The following is a description of a gene set: Any process that modulates the frequency, rate or extent of the directed movement of substances within cells. species: Mus musculus Mouse Gene Set: GOBP_REGULATION_OF_INTRACELLULAR_TRANSPORT, and this is the list of marker genes: Prkaca, Chp2, Gsk3b, Ddx39a, Mapk3, Pik3r1, Atp9a, Fez1, Gm14461, Prkcd, Ppp1cc, Asph, Arf1 (NCBI Gene Id 11840), Anxa2, Xpo1, Mapk8, Spag5, Nfkbia, Inpp5f, Mylk2, Cwh43, Pla2g3, Dynlt2b, Msn, Ncbp2, Dnajc13, Mtmr2, Pik3r2, Erlec1, Oaz3, Arv1, Akap5, Map1b, Flna, Cdk1, Nus1 (NUS1 dehydrodolichyl diphosphate synthase subunit), Pgap1, Ptpn1, Nefh, Angpt1, Hm629797 (cDNA sequence HM629797), Uhmk1, Nolc1, Nup62, Abca12, Tbc1d20, Ufm1, Rab11b, Anp32b, Bard1, Sorl1, Rab29, Numa1, Sar1a, Slc35d3, Xpo4 (NCBI Gene Id 78542), Cdc42, Yipf5, Rdx, Eipr1, Epm2a, Sh3glb1, Ubr5, Hdac3, Sirt6, Ei24, Chrm1, Nup153, Dab2 (disabled 2, mitogen-responsive phosphoprotein), Cpsf6, Prpf4b, Cnih2, Tpr, Nup54, Zfand1, Jup, Hyal2, Sirt7, Cdkn2a, Ndel1, Nrde2, Mavs, Strit1, Thoc5, Insig1, Cryaa, Pln, Vps35, Rangap1, Cryab, Zpr1, Ptpn14, Pla2g4e, Ndrg4, Hsp90aa1, Sfn, Hap1, Rbm4, Atp2a1, Pdcd5, Lcp1, Tnnt2, Mtmr4, Cabp1, Ldlrap1, Cd81, Nup214, Gripap1, Camk1, Emd, Riok2, Arhgap8, Reep1 (receptor accessory protein 1), Hrc, Nf2, Kif3a, Nsun2, Use1, B3gat3, Lmx1b, Eif3e, Rab23, Dennd10, Peg12, Mapt, Caly, Rbm22 (RNA binding motif protein 22), Sec16b, Mapk1, Inpp4b, Acacb, Lamp1, Map2, Nutf2, Ran, Supt6, Ect2 (ect2 oncogene), Nutf2-ps1, Stk11, Sh3tc2, Rab21, Snx12, Borcs5, Ipo5, Edem2, Frat1, Septin8, Kif20b, Oaz1, Pcm1, Slc51b, Ptpn23, Pcnt (pericentrin (kendrin)), Rhot1, Alkbh5, Ehd2, Lep, Abca2, Fermt1, Apod, Cdk5, Reep6, Rnf139, Capn10, Gli3, Ripor1, Arfip1, Nup58 (NCBI Gene Id 71844), Tek, Stx18, Ep300, Tmem30a, Ctdspl2, Sp100, Zc3h12a, Hnf4a, Khdrbs1, Mapk14, Os9, Setd2, Nedd4, Bmp4, Tmem30b, Ezr, Dctn1, Akap8l, Camk4, Chchd4, Atp13a2, Rufy3, Tgfb1, Trim58, Jak2, Tardbp, Snx3, Cep131, Map2k1, Scp2, Hsp90ab1, Lrrk2, Shh, Pdcd10, Trim46, Zdhhc2, Mecp2, Ywhab, Ifng, Arhgap1, Tnfrsf1a, Park7, Gper1, Frat2, Sec24b, Ptpn11, Svip, Xbp1, Edem1, Arhgap44, Gas1, Nf1, Ttc21b, Cd36, Dhx9, Cep290, Brca1, Ehd1, Vps11, Tmem53, Yod1, Pcsk9, Dync1h1, Derl3, Prr5l, Vamp2, Pdcd5-ps, Prkcq, Mdm2, Prkd1, Akap1, Derl2, Map2k2 (mitogen-activated protein kinase kinase 2), Pkia, Ube2g2, Tm9sf4, Rab11fip3, Reep2, Fam76b, Rbm10, Oaz2, Gas6, Ice1, Wipf1, Commd1, Ptpn5, Mlc1, Scfd1, Pkig, Ube2j1, Ptpn22, Trim28, Kif5b, Gcc2, Smo, Dbn1, Chp1, Mrln, Psen1, Dmap1, Chmp3, Tnnc1, Actn2 (NCBI Gene Id 73715), Cdh1, Usp7, Wnk1, Uaca, Ubac2, Ergic3, Iws1, Bag3, Tmem97, Thoc2, Zic1, Bves (blood vessel epicardial substance), Ifi27 (NCBI Gene Id 78399), Ier3, Txn1, Efcab7, Gbp4, Rab11a, Ppp1r12a, Tenm1, Plk3, Sumo1, Mdfic, Src, Ywhae, Rint1, Bcap31, Rapgef3, Ptgs2, Il6, Adipoq, Agtr2, Ppm1a, Hcls1